Given this list of marker genes COL19A1 (collagen type XIX alpha 1 chain), SLC26A4, SERPINA4, ATP8B1, EXOC4, MAGEA9, ATXN3, SUPT3H (NCBI Gene Id 8464), LECT2, APOBEC1, SGPL1, GCA, PAX6, KRT2, PGM3, NEB, BRD4, CAMK4, PDCD1, S100A5, POLR1HASP, CALN1, NPFF, ZBTB14, PCDHGB7, COL8A1, SLC4A8, F2RL3, RREB1, CDC73, SLC6A2, NTNG2, ZSCAN26, LORICRIN (loricrin cornified envelope precursor protein), IFNA10, NR3C2, KRT34, ERC2-IT1, FUT1, IL4, ADAMTSL3, FSHR, ERCC4, RXRG (NCBI Gene Id 6258), JRKL, AOC4P, TSSK2, PHOX2B, LGI1, GPR171, PVR, TMEM26, STAC, OR10H3, EDIL3, SIX6, CADM4, NHEJ1, OR2B6, PART1, TBX19, FBXL4, FZD5, CCL16, PSG1, ADAM20, OCM, CD8A, SPA17, HTR1E, ITGBL1, RAD51D, GUCY2F, here is a description of the gene set: Human Gene Set: MORF_PDCD1 species: Homo sapiens Neighborhood of PDCD1 Neighborhood of PDCD1 programmed cell death 1 in the MORF expression compendium